The following is a description of a gene set: Mouse Gene Set: WP_CHOLESTEROL_BIOSYNTHESIS species: Mus musculus Cholesterol biosynthesis, and this is the list of marker genes: Lss, Mvd, Dhcr7 (NCBI Gene Id 13360), Fdps, Nsdhl, Sc5d, Sqle, Msmo1, Fdft1, Cyp51 (NCBI Gene Id 13121, cytochrome P450, family 51), Hmgcr, Idi1, Pmvk (phosphomevalonate kinase), Mvk, Hmgcs1